Given this list of marker genes Folr2, Slc25a32, Mthfsl, Shmt2, Shmt1 (serine hydroxymethyltransferase 1 (soluble)), Aldh1l2 (NCBI Gene Id 353070), Mthfd1, Mthfs, Mthfd2l, Mthfr, Slc19a1 (solute carrier family 19 (folate transporter), member 1), Mthfd1l, Dhfr, Fpgs, Slc46a1, Mthfd2, Aldh1l1, here is a description of the gene set: Mouse Gene Set: REACTOME_METABOLISM_OF_FOLATE_AND_PTERINES species: Mus musculus Metabolism of folate and pterines